Given this list of marker genes TRIM21, FBXL14, FBXO25, FBXW11, FBXO39 (NCBI Gene Id 162517), TMEM183A, FBXL2, FBH1, FBXW5, SPSB1, FBXO17, DAW1, SPSB2, FBXO15, CUL2, FBXL17 (NCBI Gene Id 64839), FBXL6, FBXO27, FBXL20, FBXO32, CUL5, FBXW8, FBXL21P, RBX1, FBXL13, SPSB4, TMEM183BP, FBXL3, CACYBP, FBXL19, FBXO24, FBXO9, USP47, FBXL15, BTRC, CKS2, FBXW7, FBXO46, SKP1, CKS1B, FBXO48, CUL1, FBXO31, FBXO44, FBXO6, FBXL5, NCCRP1, FBXO45, AMN1, FBXO38, FBXL16, FBXO3, FBXO2, SKP2 (NCBI Gene Id 86997), FBXW4, DMAC2, FBXL7, FBXO4, FBXL4, FBXO42, SPSB3, ARIH1, FBXO7, CCNF, PRKN, here is a description of the gene set: A ubiquitin ligase complex in which a cullin from the Cul1 subfamily and a RING domain protein form the catalytic core; substrate specificity is conferred by a Skp1 adaptor and an F-box protein. SCF complexes are involved in targeting proteins for degradation by the proteasome. The best characterized complexes are those from yeast and mammals (with core subunits named Cdc53/Cul1, Rbx1/Hrt1/Roc1). species: Homo sapiens Human Gene Set: GOCC_SCF_UBIQUITIN_LIGASE_COMPLEX